The following is a description of a gene set: from publication Chen Y, Wang X (PMID 31504780) studied in species Homo sapiens Genes predicted to be targets of miRBase v22 microRNA hsa-miR-6718-5p in miRDB v6.0 with MirTarget v4 prediction scores > 80 (high confidence targets). Human Gene Set: MIR6718_5P, and this is the list of marker genes: RNF19A, MOB1A, NPC1L1 (NCBI Gene Id 29881), KPNA3, CDK17, MAN1A2, ALDH6A1 (aldehyde dehydrogenase 6 family member A1), ZRANB1 (NCBI Gene Id 54764), CACNB2, ANO5, TANC2, ADHFE1, PRKACB, KRAS, ZNF800, CHD8, VSIG1, ZNF223, GARS1, KIAA1210, MMD, HLA-F, RBSN, EGR2, UBE2V1, CAPN1, WBP1L, ZHX1, CTTNBP2, KAT2B, RIMS1, EPB41L4B, KATNBL1, PHF6, CHCHD3, GDAP1, MAGI1, HDAC7, TIPARP, FAM234B, ARF6, CCNC, TECRL, MTSS1, DYNC1I1, LHFPL2, CPT1A, CBLL1, SUSD6, TMEM115, DYNC1LI2 (NCBI Gene Id 1783), SORCS1, TSSK2, GLIPR1L2, KCNN3, ARL15, MFSD14A, ABCC4, IPO7, TENT5A, ABHD17B, UBE2G2, CNRIP1, CREB3L1, SERTAD2 (NCBI Gene Id 9792), AQP4, ARK2N, UBA6, LONRF1, RYBP, NPR3